The following is a description of a gene set: Human Gene Set: MODULE_335 studied in species Homo sapiens Genes in the cancer module 335., and this is the list of marker genes: DCT, ALAD, ALAS1, DDT, FECH, PMEL, TYRP1, HMOX1, GCLC, TYR, HMBS, HMOX2, BAAT, COX10